The following is a description of a gene set: Human Gene Set: GSE26912_TUMORICIDAL_VS_CTRL_MACROPHAGE_UP species: Homo sapiens from publication Haabeth OA, Lorvik KB, Hammarström C, Donaldson IM, Haraldsen G, Bogen B, Corthay A (PMID 21407206) The immune system can both promote and suppress cancer. Chronic inflammation and proinflammatory cytokines such as interleukin (IL)-1 and IL-6 are considered tumor-promoting. In contrast, the exact nature of protective antitumor immunity remains obscure. In this study, we have quantified locally secreted cytokines during primary immune responses against myeloma and B-cell lymphoma in mice. Strikingly, successful cancer immunosurveillance mediated by tumor-specific CD4+ T cells was consistently associated with elevated local levels of both proinflammatory (IL-1aplha, IL-1beta, and IL-6) and T helper 1 (Th1)-associated cytokines (interferon-alpha, IL-2, IL-12). Cancer eradication was achieved by a collaboration between tumor-specific Th1 cells and tumor-infiltrating, antigen-presenting macrophages. Th1 cells induced secretion of IL-1-beta and IL-6 by macrophages. Th1-derived interferon-gamma was shown to render macrophages directly cytotoxic to cancer cells, and to induce macrophages to secrete the angiostatic chemokines CXCL9/MIG and CXCL10/IP-10. Thus, inflammation, when driven by tumor-specific Th1 cells, may prevent rather than promote cancer. Genes up-regulated in macrophages: tumoricidal versus control., and this is the list of marker genes: ALAS1, CNN3, SLC25A36, BNC1, ETV1, PPL, SOCS1, HIC1, PSMD3, CYP2A6, HOXA2, ZWINT, SMPD2, NCK1, FOXN1, PDGFA, ZNF503, MGST1, CDCP1, HADH, CCDC93, SERPINB5, PLS3, RYK, RGS16, LASP1, LTBP4, GKAP1, VCL, NCKAP1, BCL2L2 (BCL2 like 2), SLC4A4, RBP1, SCHIP1, CIPC, PCCB, SKIC8, ZC3H14, BMPR1A, SERPINB4 (NCBI Gene Id 6318), FGG, MSC, TMEM150A, SIX1, CFAP418, TWSG1, INHBB, ELOVL6, ETFBKMT, COL4A2, IRF6, CRYL1, FEZ2, CDV3, FZD4, FOXO3, FBLN2, RIDA, PAWR, GNAI1, CKAP4, CCDC80, PGAM2, GAB1, GDNF, IFITM3, CTLA4, TOLLIP, SLC39A8, KRT2, PKD2, P2RX6, GJA4, CFL2, SPARC, VPS26B, PDS5B, P2RX1 (NCBI Gene Id 5023), SHROOM3 (NCBI Gene Id 57619), TBCEL, TDRP, MAOA, PLD1, CTNNA2, DNAAF5, GLRB, PTPRF, UBE2H, MT1E, LPL, DNAJC13, ST3GAL6, RAB28, RNF6, NDRG3, PLXNA2, CCK, CAPN5, JKAMP, MAN2A1, PTGS1, CDC42EP4, ALDH7A1, NKIRAS1, TIMM9, COQ9, MYPOP, DMTN, EYA1, AGTRAP, AKIRIN1, RAB34 (RAB34, member RAS oncogene family), CDH4, GJA1, NAV2, ARHGAP35, SCAMP1, TPH1, TRIM47, WNT10A, FICD (FIC domain protein adenylyltransferase), CRYBB2, ALDH3A2, SREBF1, TLE1, NISCH, RXYLT1, TULP3, CELSR1, CAVIN3, ATP2A2 (NCBI Gene Id 488), CCNJ, ZNF23, PENK, SLC32A1, TMPRSS2, ARG1, SLC46A1, DNAJB4, ANKRD46 (NCBI Gene Id 157567), ARPP19, NDUFA5, SEC16A, PTOV1, RBX1, NUDT19, GCLM, LDHB, PHAF1, CA14, KDM3A, MAPRE3, CDS2, CASP12, FASN, GPAM, TUBB4A, WWTR1, FAM83H, PLEKHA7, TMEM45A, FGF9, RHOB, SFN, DTX1, HEY1, SIPA1L2, COPZ2, DHRS3, SLTM, SLC1A4 (NCBI Gene Id 6509), DCTN1, DAB2IP, SFRP1, PLGRKT, KARS1, PTRH1, SLC6A8 (NCBI Gene Id 6535), IDO1, FN1, XPR1, PGRMC2, HDAC7, CEBPD, BPGM, CX3CL1, PAX9, FBXO15, SLC25A4, FAM3D, ZBTB2, DPF3, PPIC, S100A1, RRAS, SLC12A4, PCYOX1, GHR, HGSNAT, MAP1LC3A